The following is a description of a gene set: Cytokines mediate cell-cell communication in the immune system and represent important therapeutic targets. A myriad of studies have highlighted their central role in immune function, yet we lack a global view of the cellular responses of each immune cell type to each cytokine. To address this gap, the authors created the Immune Dictionary, a compendium of single-cell transcriptomic profiles of more than 17 immune cell types in response to each of 86 cytokines (>1,400 cytokine-cell type combinations) in mouse lymph nodes in vivo. A cytokine-centric view of the dictionary revealed that most cytokines induce highly cell-type-specific responses. For example, the inflammatory cytokine interleukin-1β induces distinct gene programmes in almost every cell type. A cell-type-centric view of the dictionary identified more than 66 cytokine-driven cellular polarization states across immune cell types, including previously uncharacterized states such as an interleukin-18-induced polyfunctional natural killer cell state. from publication Cui A, Huang T, Li S, Ma A, Pérez JL, Sander C, Keskin DB, Wu CJ, Fraenkel E, Hacohen N (PMID 38057668) studied in species Mus musculus Mouse Gene Set: CUI_CDC2_IL18_RESPONSE_DN Genes negatively differentially expressed in cell type: cDC2 (conventional dendritic cell type 2) upon treatment with cytokine: IL-18 in mouse lymph nodes in vivo., and this is the list of marker genes: Eif3e, Abca9, Klf2, Fth1, Stk38 (NCBI Gene Id 77222), Ssh2, B4galt6, Dnajb14, Clk1, Kmt2e, Arl4c, Rnf166, Skint3, Gm2a, Specc1, Otulinl (NCBI Gene Id 544676), Rassf5, Apobec1, Hexb, Xist, Add3, Kif21b, H2-Oa, Klrd1, Ckb, Hlcs, Npm1, Ramp1, Tut4, Mcemp1, Tnrc6b, Lbh, B4galnt1 (beta-1,4-N-acetyl-galactosaminyl transferase 1), Lyst, Klhl24, Arl5c, Zeb2 (zinc finger E-box binding homeobox 2), Haus8, Dhrs3, Creg1, Glud1, Prcp, Fosb, Smarca2, Arhgap25, Pfkfb3, Siva1, Il17ra, Pstpip1, Uba52, Amz1, Stap1, Nr2c2, Nr4a2, Wasf2, Egr1, Laptm5, Slc66a2, Rgs10, Higd2a, Tmcc1, Mob3b, Ccdc88a, Igsf6 (immunoglobulin superfamily, member 6), Pip4k2a, Ucp2, Tnfsf9, Rcsd1 (RCSD domain containing 1), Stard9, Tbc1d4, Bnip3l, Rgs18, Plekhg3, Trim7, Cx3cr1, Bri3, Ctsh, Pirb, Colgalt1, Brd3, Ccnd1, Ier2, Plekhm3, Tnfaip8, Arhgap9, Git2, Pabpc1, Tsc22d3, Fbrsl1, H1f2, Rgs2 (regulator of G-protein signaling 2), Smim5, Lmo4, Pnrc1, Mbnl1, Supt4a, Ccl9, Grk3, Pmaip1, Txnip, Cerk (NCBI Gene Id 223753), H2az1, Atp5mc2, Map3k1, Mapk14, Slc43a2, Klf4, Susd3, Mxd4, Adcy7, Mink1, Sod1, Eif4ebp2, Cyp27a1, Cd244a, Arrb1, Il1b, Fam107b, Neat1, Zfp36l1, Akap13, Gdi2, Selplg, Taok3, Ccni, Arhgap45, Polr2e, Tnfrsf1b, Ankrd44, Eef1a1, Eif3f, Arhgef6, Sat1, Rin2, Smpdl3a, Ighm, Plxnd1, Rmnd5a, Trappc5, Clec4a2, Spn (NCBI Gene Id 20737), Pold4, Ppfia4, St8sia6, Lsp1, Cd300c2 (NCBI Gene Id 140497), Zfp36l2, Sox4, Uvrag, Elk3, Nav1, Dipk1a, Tlr2, Slc38a1, Nr4a1, Ptms, Stk17b, Man2b1, Apbb1ip, Cxcr4, Atp5if1 (ATP synthase inhibitory factor subunit 1), Ptpn22, Ypel3, Celf2, Kctd12, St8sia4, Il13ra1, Eif4ebp1, Ccpg1, Mef2c, Erp29, Lmo1, Sirpa, Rsrp1, Il6st, Lactb, Foxp1, Cdkn1b, Hbp1, Clec4b1, Eif4b, Spib, Junb, Flt3, Prdx6, Pid1, Btg2, Mknk2, Gpx1, Il16, Nfkbiz, Alcam, Bmyc, Jup, Ifngr1, Tent5a, Pou2f2, Gpr68, Slc46a3, Tfeb, Lpin1, Itgb7, Dhrs7, Tbc1d9, Nfam1, Limd2, Eef2, Nek7, Ppp1r15a, Calhm2, Macf1, Tpm1, Ehf, Avpi1, Gpi1, Stk10, Tmem50a, Vsir, Rnf130 (NCBI Gene Id 80609), Il6ra, Cox7a2l, Pdcd4, Stard5, Hscb, Map3k4, Deptor, Sla, Shtn1, Tspan33, Marveld1, Alox5ap, Kdm7a, Zfp36, Dusp1, Rassf3, Aph1c, Nectin1, Fos, Niban1